Given this list of marker genes C2CD5, PTPN1, CUL3 (cullin 3), PLA2G2A, SYAP1, SRD5A2, NR1H4, RETN, SP7, PID1, GDF15, AGTRAP, ALPL, MDM2, CEACAM1, JAK3, CSF2RA (NCBI Gene Id 8282), GSK3A, ERRFI1, CDC6, VWA2, VPS13C, REG3A, NFKB1, GNAI1, MIR379, SP1, NR5A1, MYO5A, ACTN2, GLP1R, SIRT1, STAT4, STAT5A, SERPINA12, SGCB, HMGCS2, PNPLA3, GNRH1, CRHR2, CXCL12, PLCB1, GHRL, PKLR, ROCK1, EDNRB (endothelin receptor type B), EIF4EBP2, NCK1, GCGR, PRKDC (protein kinase, DNA-activated, catalytic subunit), PHEX, CFL1, FBN1, CRY1, CSH1, INSIG2, TSC1, ERFE, MBD5, REG1B, ITGB3, CACNA2D3, GSTP1, PXN, SRSF6, SRC, EDNRA, SLC22A12, SHOC2 (SHOC2 leucine rich repeat scaffold protein), MIR103A1, DAG1, HADHA, ACVR1C, MAPK3, CA2, GRB14, CPS1, PTK2, MIR195, IGFBP1, CPEB1, IL10, NKX6-1, MSTN, CSRP3, MEAK7, NCL, CRY2, LONP1, IRS4, GHSR, SIK2, GAL, NEFL, AANAT, SREBF1, LYN, SRSF5, PRKCZ, PDK2, LPIN1, FOXC2, APPL1, BAIAP2, PCSK9, CFLAR, SMARCC1, LEP, UCP3, RHOQ, LTA4H, EIF2B4, GAB1, REG3G, SORT1, NCOA5, EDN1, KCNQ1, MGARP, SESN3, IRS2, RPS6KB1, LPIN2, TRARG1, IDE, RAB31, PRKCQ, NPPA, FOS, ROCK2, CCNA2, SMAD3, EIF2B3, DDR2, PTPN11, BTG1, STAT1, MIR1271 (NCBI Gene Id 100302203), GH1, DNAI1, SLC25A33, AREG, MIR15B, UMODL1, TRPV4, DENND4C, CSH2, CTSD, STXBP4, GLP2R, INPP5K, ENPP1, POMC, IGF2, TRIM72, NCOA2, FOXO4, RB1, RBP4 (retinol binding protein 4), HRAS, SLC30A10, EIF2B1, PCK1, PDE3B, SLC27A4, FUT1, PIP4K2C, ALAS1, GPLD1, IL1B, SESN2, PKM, ZBTB7B, NR4A3, TGFB1, BSG, PIK3C2A, EREG, CAV2, GCG, SHC1, KHK, MIR143, PAK1 (p21 (RAC1) activated kinase 1), UPRT, RBM4, SNX5, BMP7, NAMPT, ASS1 (NCBI Gene Id 445), NPR2, REG1A, NFE2L2, CYBB, OPRK1, TBC1D4, GNRHR, OTC, F7, SOS2, CRHR1, JUND, PRKACA, IGFBP5, PLA2G1B, GOT1, PRLH, POU4F2, PLN, AKT1, SLC24A4, COL3A1, HSD11B2, SH2B2, PARP1, TRIM24, ZBED3, TSC2, GRB2, INHBA, CD2AP, EPM2AIP1, JAK1 (Janus kinase 1), BGLAP (NCBI Gene Id 632), RARRES2, MIR27B, TFF1, PRKCD, GALP, SOCS1, PIP4K2A, GH2 (NCBI Gene Id 2689), CYP11B2, AGTR2, PRKAR1A, SLC9A1, TYK2, VGF, PIP4K2B, MC4R, INSR, CREB1, INPPL1, COL6A1, CAT, PIK3CA, RAB13, TRIM16 (NCBI Gene Id 10626), SCNN1A (sodium channel epithelial 1 subunit alpha), SELENOS, COMT, LRP5, LEPROT, INSRR, PPARG, PRKCB, SCAP, TSHR, GSK3B, CAD, RANGAP1 (Ran GTPase activating protein 1), MTCL2, CDO1 (NCBI Gene Id 105379131), EPRS1, INSIG1, ADCY8, PIK3R2, RAF1, HADH, SCNN1D, PPP3CA, SORBS1, MZB1, INHBB, CAV1, MAPK1, EGR1, SLC2A1, NR4A2, EIF2B2, LRP6, NCOA1, ADIPOQ, APC, NR4A1, CPEB2, STAT5B, PDPK1, RAB10, PTPRE, FAM114A1, USF1, BCAR1, HNF4A, PRKD1, EIF2B5, AGRP, OXT, NONO, PNPT1, SRD5A1, AP3S1, GHR, POR, INS, GPR21, SCNN1B, RAP1GDS1, FYN, TNFRSF11A, AHSG, CYP11A1, MYO1C, PPARA, KCNJ8, GRB7, TRIB3, EEF2K, MAP3K7, FFAR3, NUCKS1, MAS1, MTOR, STAT6, MAPKAP1, SLC39A14, OGT, FER, SRSF4, IRS1, CYBA, CUL7, RELA, WNT1, AGT, CELA2A, SCNN1G, ABCC8, HDAC5, PIK3R1, FUT7 (NCBI Gene Id 2529), STXBP3, PRKAA1, CRK, PRKCG (NCBI Gene Id 57013), KLF15, LPIN3, PRKCI, PTPN2, STC2, PCK2, YWHAG, HSF1, ZNF106, RBX1, IGF1R, GPER1 (NCBI Gene Id 2852), EIF6, RPS6, CITED1, UCP2, KBTBD2, JAK2, TGFBR3, SOS1, SLC34A1, RAB8A, ADIPOR1, GCNT1, XBP1, KAT2B, ACE, BLVRB, GKAP1 (NCBI Gene Id 80318), APPL2, GRB10, FOXO1, CAMK2A, PDK4, TIMP1, OSBPL8, WDTC1, MIR145, USO1, ADCY6, MIR107, KL, TNS2, PRKCA, IGF1, TOP1, NDEL1, MAP1B, SLC2A4, CYC1, ZFP36L1, RAC1, GHRHR, SLC2A8, ABCB1, GPR82, ATP2B1, RPS6KB2, GNRHR2, SORL1, SLC26A6, G6PC1, KANK1, HDAC9, FBXW8, SOCS3, AKT2, TCF12, SOCS7, PTPRJ, GCLC, SOCS2, BCAR3, COL1A1, CHUK, LEPROTL1 (NCBI Gene Id 23484), SLC27A1, GRIA1, FAT1, CAPN10, PIK3R3 (phosphoinositide-3-kinase regulatory subunit 3), ZNF592, CACYBP, MAPK14, BTG2, VAMP2, STAT2 (NCBI Gene Id 6773), CSHL1, CSK, CYP11B1, MT-CYB, PHIP, NUDC, GCK, AHCYL1, ZDHHC7, FABP3, STAT3, ECHDC3, OTOP1, GPR173, LHCGR, CRHBP, C1QTNF12, FBP1, AGTR1, GNAS, here is a description of the gene set: Human Gene Set: GOBP_RESPONSE_TO_PEPTIDE_HORMONE Any process that results in a change in state or activity of a cell or an organism (in terms of movement, secretion, enzyme production, gene expression, etc.) as a result of a peptide hormone stimulus. A peptide hormone is any of a class of peptides that are secreted into the blood stream and have endocrine functions in living animals. species: Homo sapiens